The following is a description of a gene set: Autoimmunity Human Gene Set: HP_AUTOIMMUNITY studied in species Homo sapiens The occurrence of an immune reaction against the organism's own cells or tissues., and this is the list of marker genes: RHCE, PXK, HLA-DQB1 (major histocompatibility complex, class II, DQ beta 1), COL4A6, MST1, STAT4, ANKRD55, RNU7-1, COLQ, ARHGEF1, TPP2, PNP, TXNRD2, TTC7A, SERPINA1, COPA, FOXP3, RNASEH2A, CD19, LMNB2, IRAK1, DEF6, SBDS, STING1, CHRND, PLCG1, KDM6A, POMP (proteasome maturation protein), GPR35, HLA-B, GRIN2A, SMAD2, BANK1, AGRN, LCK, C3, IGHG2, THRB, SOCS1, WAS, JAZF1, MAGT1, NBN, TCIRG1, NFKBIL1, STK4, FAS, PIK3R1, LAT, IL7R, TNPO3, COMT, HR, MTHFD1, ICOS, FMR1, COL13A1, LIG4, CBLB, ARPC5, KCNJ11, IFNG, TLR8, MECP2, CD3G, NLRP1, STIM1, GNAS, FADD, TNFSF4, SLC12A3, C1R (NCBI Gene Id 791254), NARS2, C8A, CASP10, CFTR, LRBA, GALE, PLAGL1, GNE, ADAR, MMP2, RAPSN, ABCC8, SYT2, SLC22A4 (solute carrier family 22 member 4), SPP1, CTNNB1, HNF4A, MYO9A, HLA-DRB1, TNFRSF13B, SPATA22, ICOSLG, SEC24C, ABCB11, HLA-DPA1, SNAP25, TLR7, UBE2L3, PTPN22, CIITA, IRF2BP2, WIPF1, HYMAI, JMJD1C, SLC25A1, FLT1, PSMG2, TCF4, DOCK11, FOXE1, IL2RA, CLPB, TBX1, C1QC, IL6, CALR, CTNNBL1 (catenin beta like 1), C1QB, ACTB, FCGR2B, CCN6, CDKN1B, PRKCD, CHRNB1, POU2AF1, CR2, RFX5, IGHG1, CHRNA1, PAX4, DDX41, ETS1, DOK7, SEMA6B, TBX2, STAT3, TRHR, ZAP70, LACC1, RMRP, PEPD, GALC, GLIS3, PRF1, KMT2D, NNT, CRYAB, C2, SAMHD1, TAP2, GP1BB, MS4A1, MRAP, HIRA, DOCK8, PGM3, RFXANK, NRAS, C1S, AKT2, PDCD1, NFKB1, PRTN3, CD247, NFKBIA, RAG1, SEC23B, POLG (DNA polymerase gamma, catalytic subunit), IL10, ITGAM, ALG14, ATP8B1, SHARPIN, ELANE, CHD7, LSM11, RHD, TNFRSF13C, ITPR3, SLC5A7, TNFAIP3, FCGR2C, ARPC1B, FCGR2A, CAV1, ACP5, TERC, RAG2, CSF2RA, SLC7A7, SPIB, TET2, CCN2, PREPL (NCBI Gene Id 9581), NEUROD1, PIK3CD, LYN, PI4KA, MIF, MASP2, ARVCF, FOXN1, IL18BP (interleukin 18 binding protein), C4B, CTLA4, LBR, CD81, PIK3CG, TRAPPC2, C1GALT1C1 (NCBI Gene Id 29071), TBK1, STOX1, TREX1 (NCBI Gene Id 82474), CHRNE, IFIH1, FASLG, RFXAP, C1QA, PLEC, IL2RB, PTEN, NFKB2, TNIP1, KRAS, MC2R, KLF11, TSHB, MMEL1, RIPK1, IGKC, DRG1, SMPD1, CYBC1, SCN4A, TRMT10A, CSF2RB, EIF2AK4, RREB1, COL4A5, STX16, ITCH, SERPING1, ZFP57, CD244, NR1H4, SEMA4D, ADA2, SASH3, LEMD3, RNASEH2C, ABCB4, NHEJ1, VAMP1, SAT1, IL12RB1, JAK2, STAR, ADA (NCBI Gene Id 100), TNFSF15, RNASEH2B, LCP2, SLC18A3, IRF5, CARD10, DCLRE1C, RASGRP1, STAT1 (NCBI Gene Id 6772), SMARCAL1, BACH2, UFD1, DUT, MYT1L, DNASE1L3, TNFSF12, PRG4, PLCG2, IKBKG, DNASE1, CLCNKB, APPL1, PDX1, INS, KIAA0319L, FOXD3, IL2RG, HAVCR2, TRAC, CORIN (corin, serine peptidase), BLK, MUSK, AIRE, TSHR, GCK (glucokinase), MPL, CMPK2, FCGR3B, CHAT, TERT, GFI1, C4A, UBA1, CEL, DNAJC3, BTK, ITK, HLA-DPB1, IFNGR1, PTPN2, IL12A (NCBI Gene Id 3592), SRP19, MPV17, HNF1A, CCR6, RHAG